The following is a description of a gene set: Human Gene Set: HP_FIBULAR_HYPOPLASIA species: Homo sapiens Underdevelopment of the fibula. Fibular hypoplasia, and this is the list of marker genes: CEP120, AMER1, ATR, COL11A1, SOX9, PTH1R, SLC35D1, AFF3, FZD2, SHOX, INTU, IFT122, COG4, INPPL1, BMPR1B, SMOC1, DYNC2H1, EIF4A3, AFF4, SF3B4, FLNA, BHLHA9, GPC6, GDF5, MET